Given this list of marker genes Rbm24, Cyp26b1, Nln, Hdac9, Hdac4, Hdac5, Tbx1, here is a description of the gene set: Mouse Gene Set: GOBP_REGULATION_OF_SKELETAL_MUSCLE_FIBER_DIFFERENTIATION Any process that modulates the frequency, rate or extent of skeletal muscle fiber differentiation. species: Mus musculus